Given this list of marker genes RNF125, ELK3, HLF (HLF transcription factor, PAR bZIP family member), HLA-DRB4, DRAM1, SLC25A36, SPTBN1, PPP1R16B, TFPI, BCL11A, ALCAM, CRHBP, HOXB2, HOXB3, FRMD4B, HTR1F, PRKCH, RBPMS, TCEAL9 (transcription elongation factor A like 9), HOXA5, KAT6A, YES1, MEIS1, FLT3, TMEM38B, ZNF165, FAM30A, SOCS2, SPINK2, CACNB2, SMARCA1, ERG, MECOM, MYO5C, INPP4B, BAALC, PLSCR4, GUCY1A1, DAPK1, ABCB1, ADGRG6, here is a description of the gene set: from publication Eppert K, Takenaka K, Lechman ER, Waldron L, Nilsson B, van Galen P, Metzeler KH, Poeppl A, Ling V, Beyene J, Canty AJ, Danska JS, Bohlander SK, Buske C, Minden MD, Golub TR, Jurisica I, Ebert BL, Dick JE (PMID 21873988) species: Homo sapiens Xenograft studies indicate that some solid tumors and leukemias are organized as cellular hierarchies sustained by cancer stem cells (CSCs). Despite the promise of the CSC model, its relevance in humans remains uncertain. Here we show that acute myeloid leukemia (AML) follows a CSC model on the basis of sorting multiple populations from each of 16 primary human AML samples and identifying which contain leukemia stem cells (LSCs) using a sensitive xenograft assay. Analysis of gene expression from all functionally validated populations yielded an LSC-specific signature. Similarly, a hematopoietic stem cell (HSC) gene signature was established. Bioinformatic analysis identified a core transcriptional program shared by LSCs and HSCs, revealing the molecular machinery underlying stemness properties. Both stem cell programs were highly significant independent predictors of patient survival and were found in existing prognostic signatures. Thus, determinants of stemness influence the clinical outcome of AML, establishing that LSCs are clinically relevant and not artifacts of xenotransplantation. Human Gene Set: EPPERT_CE_HSC_LSC Shared human hematopoietic stem cell (HSC) and acute myeloid leukemia (AML) stem cell (LSC) genes: HSC genes that are highly expressed in LSC versus other leukemic cells.